The following is a description of a gene set: This event has been computationally inferred from an event that has been demonstrated in another species.<p>The inference is based on the homology mapping from PANTHER. Briefly, reactions for which all involved PhysicalEntities (in input, output and catalyst) have a mapped orthologue/paralogue (for complexes at least 75% of components must have a mapping) are inferred to the other species. electronically inferred by orthology from the curated human pathway studied in species Mus musculus part of: Regulation of PD-L1(CD274) Post-translational modification Reactome Pathway: AMPK-induced ERAD and lysosome mediated degradation of PD-L1(CD274), and this is the list of marker genes: Rps27a, Psma4, Derl1, Derl3, Psmd13, Psma6, Psma1, Sel1l, Psmc2, Ubb, Prkag1, Psmc5, Psmb5, Psma2, Psmd6, Psmc3, Psmd7, Psma7, Psmc6, Psma3, Psmc4, Psmb6, Prkag3, Psmb4, Psmd12, Vcp, Psmd1, Psmc1, Psmb7, Cd274 (CD274 antigen), Psma5, Erlec1